The following is a description of a gene set: Cellular proliferation, growth, apoptosis and Wnt signaling genes up-regulated in SNU638 cells (gastric cancer) by overexpression of SFRP2 off a plasmid vector. species: Homo sapiens Activation of Wnt signaling has been implicated in gastric tumorigenesis, although mutations in APC (adenomatous polyposis coli), CTNNB1 (beta-catenin) and AXIN are seen much less frequently in gastric cancer (GC) than in colorectal cancer. In the present study, we investigated the relationship between activation of Wnt signaling and changes in the expression of secreted frizzled-related protein (SFRP) family genes in GC. We frequently observed nuclear beta-catenin accumulation (13/15; 87%) and detected the active form of beta-catenin in most (12/16; 75%) GC cell lines. CpG methylation-dependent silencing of SFRP1, SFRP2 and SFRP5 was frequently seen among GC cell lines (SFRP1, 16/16, 100%; SFRP2, 16/16, 100%; SFRP5, 13/16, 81%) and primary GC specimens (SFRP1, 42/46, 91%; SFRP2, 44/46, 96%; SFRP5, 30/46, 65%), and treatment with the DNA methyltransferase inhibitor 5-aza-2'-deoxycytidine rapidly restored SFRP expression. Ectopic expression of SFRPs downregulated T-cell factor/lymphocyte enhancer factor transcriptional activity, suppressed cell growth and induced apoptosis in GC cells. Analysis of global expression revealed that overexpression of SFRP2 repressed Wnt target genes and induced changes in the expression of numerous genes related to proliferation, growth and apoptosis in GC cells. It thus appears that aberrant SFRP methylation is one of the major mechanisms by which Wnt signaling is activated in GC. from publication Nojima M, Suzuki H, Toyota M, Watanabe Y, Maruyama R, Sasaki S, Sasaki Y, Mita H, Nishikawa N, Yamaguchi K, Hirata K, Itoh F, Tokino T, Mori M, Imai K, Shinomura Y (PMID 17297461) Human Gene Set: NOJIMA_SFRP2_TARGETS_UP, and this is the list of marker genes: HSPA6, TNN, TNFAIP3, CIDEC, IL24, TNFRSF10D, TNFRSF9, INHBE, IKBKG, CLU (clusterin), GADD45A, HSPA9, DEDD2, TP53AIP1, HSPA1A, TRIB3, PPP1R15A, MXD1, NR4A3, CSF1, JUN (NCBI Gene Id 3725), HSPA1B, BAG3 (BAG cochaperone 3), GADD45B, CLK1, WARS1, BTG1, HSPA5, CCN2, CD40, SFRP2, VHL